The following is a description of a gene set: studied in species Homo sapiens Hematopoietic stem cell gene regulation by GABP alpha/beta complex Human Gene Set: WP_HEMATOPOIETIC_STEM_CELL_GENE_REGULATION_BY_GABP_ALPHABETA_COMPLEX, and this is the list of marker genes: TERF2, DNMT3A, MCL1, GABPB1, DNMT3B, SMAD4, DNMT1, ZFX, BCL2, PTEN, ADAMTSL4-AS1, GZMB, FLT3, ATM, GABPA, FOXO3, CREBBP, SMARCA4, BCL2L1, EP300, ETV6